The following is a description of a gene set: studied in species Mus musculus electronically inferred by orthology from the curated human pathway Reactome Pathway: Formation of the Early Elongation Complex This event has been computationally inferred from an event that has been demonstrated in another species.<p>The inference is based on the homology mapping from PANTHER. Briefly, reactions for which all involved PhysicalEntities (in input, output and catalyst) have a mapped orthologue/paralogue (for complexes at least 75% of components must have a mapping) are inferred to the other species. part of: RNA Polymerase II Transcription Elongation, and this is the list of marker genes: Polr2e, Polr2l, Gtf2f2, Ercc3, Ccnh, Polr2c, Supt5, Ctdp1, Gtf2f1, Nelfa, Polr2i, Polr2b, Polr2a, Ercc2, Polr2f, Supt4a, Gtf2h2, Gtf2h4, Polr2k, Nelfe